The following is a description of a gene set: Human Gene Set: GOCC_DENSE_BODY An electron dense body which may contain granules. species: Homo sapiens, and this is the list of marker genes: ACTB, PIWIL1, SND1, ACTG1, PIWIL2